Given this list of marker genes GATA2, CDK6, SFRP1, FBXW7, TNFRSF11B, ZBTB46, PRDM16, ERFE, PTPN2 (protein tyrosine phosphatase non-receptor type 2), TOB2, ZNF675, MAFB, ADIPOQ, RARA, FSTL3, TAOK3, ZFPM1, INHA, APCS, LTF, GPR55, LILRB4, LYN, GPR68, TLR4, QKI, IAPP, MIR486-1, INHBA, INPP5D, MIR125B1, UBASH3B, PIK3R1, CALCA, TLR3, GPR137, TCTA, FBN1, CEACAM1, CTNNB1, GPR137B, LRRC17, LILRB3, LILRB1, PIAS3, CLDN18, TMEM178A, MYC, CARTPT, NF1, TNFAIP6, CUL4A, C1QC, CCL3, HOXA7, TRIB1, IL4, RUNX1, here is a description of the gene set: studied in species Homo sapiens Any process that stops, prevents, or reduces the frequency, rate, or extent of myeloid leukocyte differentiation. Human Gene Set: GOBP_NEGATIVE_REGULATION_OF_MYELOID_LEUKOCYTE_DIFFERENTIATION